The following is a description of a gene set: Human Gene Set: GOCC_NEUROFILAMENT studied in species Homo sapiens A type of intermediate filament found in the core of neuronal axons. Neurofilaments are heteropolymers composed of three type IV polypeptides: NF-L, NF-M, and NF-H (for low, middle, and high molecular weight). Neurofilaments are responsible for the radial growth of an axon and determine axonal diameter., and this is the list of marker genes: HTR2A, NEFL, NRP1, DYRK1A, LDLRAP1 (NCBI Gene Id 81862), DLGAP2, INA, SHANK2, NEFM, NEFH, CLDN11